Given this list of marker genes Rab1a, Tubb2b, Ank1, Copz1, Tubb4a, Cog5, Arf1, Copg2, Arcn1, Arfgap1, Spta1, Dync1li2, Cog8, Cog2, Gbf1, Tmed9, Arf3, Tubb4b, Kdelr3, Arf5, Tuba3b, Dctn5, Gosr1, Rab1b, Capza3, Ykt6, Kdelr2, Napg, Sptbn1, Copb1, Actr1a, Sptbn2, Tmem115 (transmembrane protein 115), Gosr2, Napb, Folr1, Dctn3, Tuba1b, Napa, Nsf, Tuba8, Copa, Dctn4, Dync1li1, Golga2, Tuba1c, Tubb2a, Dynll2, Tmed7, Cope, Dctn1, Tubal3, Cog7, Dync1i1, Cd55, Gorasp1, Tubb3, Copb2, Actr10, Stx5a, Cog6, Tmed3 (NCBI Gene Id 66111), Bet1l, Ins1, Capzb, Arfgap2, Kdelr1, Dctn2, Sptbn4, Tmed2, Copg1, Dync1i2, Sptb (NCBI Gene Id 383567), Sptan1, Cog1, Cog4, Tuba3a, Copz2, Dynll1, Tuba1a, Cog3, Arfgap3, Tuba4a, Tubb6, Tmed10, Capza2, Sptbn5, Cd59b, Dctn6, Golgb1, Tubb1, Bet1, Dync1h1 (NCBI Gene Id 319904), Uso1, Arf4, here is a description of the gene set: species: Mus musculus COPI-mediated anterograde transport Mouse Gene Set: REACTOME_COPI_MEDIATED_ANTEROGRADE_TRANSPORT